The following is a description of a gene set: Up-regulated genes from the set E (Fig. 5a): specific signature shared by cells expressing either MLL-AF4 or AF4-MLL fusion proteins alone, and those expressing both fusion proteins. species: Mus musculus from publication Gaussmann A, Wenger T, Eberle I, Bursen A, Bracharz S, Herr I, Dingermann T, Marschalek R (PMID 17130830) The reciprocal chromosomal translocation t(4;11) is correlated with infant, childhood, adult and therapy-related high-risk acute leukemia. Here, we investigated the biological effects of MLL.AF4, AF4.MLL or the combination of both reciprocal fusion proteins in a conditional in vitro cell culture model system. Several parameters like cell growth, cell cycling capacity, apoptotic behavior and growth transformation were investigated under physiological and stress conditions. Co-transfected cells displayed the highest resistance against apoptotic triggers, cell cycling capacity and loss-of-contact inhibition. These analyses were complemented by gene expression profiling experiments and specific gene signatures were established for each of the three cell lines. Interestingly, co-transfected cells strongly upregulate the homeobox gene Nanog. In combination with Oct4, the Nanog homeoprotein is steering maintenance of pluripotency and self-renewal in embryonic stem cells. Transcription of Nanog and other stem cell factors, like Oct4 and Bmi1, was verified in biopsy material of t(4;11) patient cells which express both reciprocal t(4;11) fusion genes. In conclusion, the presence of both reciprocal MLL fusion proteins confers biological properties known from t(4;11) leukemia, suggesting that each of the two fusion proteins contribute specific properties and, in combination, also synergistic effects to the leukemic phenotype. Human Gene Set: GAUSSMANN_MLL_AF4_FUSION_TARGETS_E_UP, and this is the list of marker genes: RAB40B, C1S (NCBI Gene Id 716), GAL3ST4, CRYAB (crystallin alpha B), S100A10, IFIT1B, RCAN2, CLEC11A, SERPINA3, CRIP1, YIPF5, MTUS2, CTHRC1, NUDT7, SFRP1, ISLR, NPNT, TGFBI, KDM6A, NIPAL4, ADM, PROCR, IL13RA1, LMCD1, BEND5, SFRP2, RGCC, COLEC12, GCA, PMAIP1, SVEP1, ABCA1, CTBS, ZC2HC1A, MYO1B, PPIG, TMT1A (NCBI Gene Id 25840), PDGFRL, IL7, PLB1, MEDAG, FOS, CLU, FABP3, CD34, POSTN, CXCL6, SERPINB6, CDH11, SORCS2, FOXRED2, L1CAM, SLC5A7, RASL11A, HDAC9, ID4, ASB5, BVES, KCTD12, HEY1 (hes related family bHLH transcription factor with YRPW motif 1), PDGFRA, RNF144B, KCNF1, CCL5, ATP1B1, SEMA3B, GNRHR, HAS2, RIOX1, ADGRG2, MAN1C1, SULF1, FLRT3, SLC38A4, EGR3, CARNS1, NREP, CYP7B1, ENPP1, AKIP1, NTN1 (NCBI Gene Id 9423), ASPN, ADGRE5, INTS12, SORBS2, OCIAD2, HSPA1B, CDH3, CP, SLC1A6, GRB14, PCDHB4, TBX20, PTN (pleiotrophin), CEMIP, EPHA1, GAS2, PDE10A